Given this list of marker genes FLOT2, FAS, CDC37, UBA52, RIPK1, UBC, TNFRSF10B, MLKL, ITCH, TNFRSF10A, UBE2L3, HSP90AA1, TRAF2, CFLAR, FLOT1, FADD, STUB1, TNFSF10 (NCBI Gene Id 8743), PELI1, XIAP, BIRC3, RIPK3, TRADD, CASP8, FASLG, RPS27A, PRKN, PDCD6IP, UBB, SDCBP, BIRC2, OGT, here is a description of the gene set: Human Gene Set: REACTOME_RIPK1_MEDIATED_REGULATED_NECROSIS RIPK1-mediated regulated necrosis studied in species Homo sapiens